The following is a description of a gene set: studied in species Homo sapiens Talipes valgus Outward turning of the heel, resulting in clubfoot with the person walking on the inner part of the foot. Human Gene Set: HP_TALIPES_VALGUS, and this is the list of marker genes: SCN2A, FGF13 (NCBI Gene Id 730528), SCN1A, LIFR, CHMP1A, SCN9A, STX1B, RAB3GAP2, DNMT3A, GABRD, CARS1, NONO, EXT2, PRRT2, EXT1, MAN2B1, HCN1, GABRG2, HNRNPH1, ADGRV1, SCN1B